Given this list of marker genes Apoc1, Nudc, Epcam, Krtdap, Cdk1, Smc4, Rps10, Calr, Krt16, Rpl12, Rpl28, Hmgb2, Pfdn6, Spc24, Tubb6, Ube2m, Lgals3, Ccnb2, Lypd3, Ovol1, Pbk, Nme2, Plac9, H2-D1 (NCBI Gene Id 547343), Dut, Serpinb3a, Ifi27l2a, Smc2, Gsta4, Sprr1b, Rpsa, Cdca8, Sfn, H2ac23, Cdca3, Rps20, Tubb4b, Ptms, Fosl1, Ier3, Nme1, Tpi1, Mgst1, Arl6ip1, Nhp2, Stmn1, Ehf, Tagln2, Ifi202b, Gm94, Vsig8, Apoe, Cxcl16, Rpl13a (ribosomal protein L13A), Tuba1b, Ccl2, Tsc22d1, Fkbp2, Tyms, Gadd45b, Ptges3, H2-K1, Rplp1, S100a14, Tacc3, Slc25a3, Top2a, Birc5, Ccnb1, Cxcl1, Eef1b2, Plaur, Zfand5, Jpt1 (Jupiter microtubule associated homolog 1), Fabp5, Pebp1, Ddx39a, Pnrc1, Ldha, Ptma, Selenbp1, Slurp1, Ube2c, Shroom3, Hcar2, Nusap1, Ccna2, Tubb5, Cks2, Nfkbia, Tacstd2, Rbm3, Gpx2, Aldh3a1, Krt36, Tpt1, Krt6b, Gstm1, Cox5a, Racgap1, Ifitm3, Pclaf, Ube2s, Fdps, Incenp, Rangap1 (NCBI Gene Id 97970), Tgm3, Cldn4, H2az1, Csnk2b, Sbsn, Rps12, Ran, Hint1, Adh7, Cdc20, B2m, Stx11, Ptgr1, Prc1, Wdr89, H2ax, Cks1b, Ifi27, Rpl5, Cysrt1, Snhg12, Selenoh, Tk1, Pgk1, Tle5, Ccl20, Rps21, Plet1, Phlda1, Rplp2, Tuba4a, Rack1, Gsto1, Ly6d (NCBI Gene Id 17068), Cxcl10, Tuba1c, Pmm1, Atf4, Sod1, Ppa1, Cenpa, Slpi, here is a description of the gene set: studied in species Mus musculus from publication Tabula Muris Consortium (PMID 32669714) Mouse Gene Set: TABULA_MURIS_SENIS_TONGUE_BASAL_CELL_OF_EPIDERMIS_AGEING